Given this list of marker genes CYP2F1, NR1H3, TNNC2, SLC25A13, IL1RAP, SLC2A2, PNLIP, SLC27A5, TNNT3, TRPV2, PON1, EHHADH, REG1A, RGN, CYP7A1, PEX11A, PLA2G1B, HPD, AASS, OAT, BHMT, ALOX12B, CYP4F2, WNT10B (Wnt family member 10B), CYP2E1, NDRG2, KRT4, TNNI2, CYP7B1 (NCBI Gene Id 9420), SLC1A2, HSD3B2, MAT1A, PAH, GSTO1, HOXA5, PCK1 (NCBI Gene Id 5105), DMBT1, MCM10, CSAD, CTRC, ACOX1, PADI4, ELANE, ACSL1, GPR37, EPHX2, FABP1, ALDH3A2, CA5A, PRODH, SELENBP1, DPYS, AKR1C1 (aldo-keto reductase family 1 member C1), C4BPA, OTC, GLYAT, PHYH, PNLIPRP1, G6PC1, GCDH, CPT2, LACTB2, ABCD3, BAAT, RORC, ME1, ACADSB, NETO2, ACSM3, MYH1, LIPC, ALDH1A1, CA3, DCXR, here is a description of the gene set: Genes down-regulated in hepatocellular carcinoma (HCC) induced by diethylnitrosamine (DENA). Human Gene Set: LEE_LIVER_CANCER_DENA_DN Genetically modified mice have been extensively used for analyzing the molecular events that occur during tumor development. In many, if not all, cases, however, it is uncertain to what extent the mouse models reproduce features observed in the corresponding human conditions. This is due largely to lack of precise methods for direct and comprehensive comparison at the molecular level of the mouse and human tumors. Here we use global gene expression patterns of 68 hepatocellular carcinomas (HCCs) from seven different mouse models and 91 human HCCs from predefined subclasses to obtain direct comparison of the molecular features of mouse and human HCCs. Gene expression patterns in HCCs from Myc, E2f1 and Myc E2f1 transgenic mice were most similar to those of the better survival group of human HCCs, whereas the expression patterns in HCCs from Myc Tgfa transgenic mice and in diethylnitrosamine-induced mouse HCCs were most similar to those of the poorer survival group of human HCCs. Gene expression patterns in HCCs from Acox1(-/-) mice and in ciprofibrate-induced HCCs were least similar to those observed in human HCCs. We conclude that our approach can effectively identify appropriate mouse models to study human cancers. from publication Lee JS, Chu IS, Mikaelyan A, Calvisi DF, Heo J, Reddy JK, Thorgeirsson SS (PMID 15565109) species: Homo sapiens